Given this list of marker genes Atp6v1b2, Mnat1, Ino80 (INO80 complex subunit), Zfp970, Styxl2, Slc5a10, Pigw, Gtf3c4, Ido2, Pten, Alad, Lrp5, Ppp1r1c, Saysd1, Pusl1, Stat5b, Tbx20, Zfp966, Aff4, Nr3c1, Zfp979, Hspa5, Rad23b, Azin1, Retn, Rbm46, Gcsh, Arx, Txndc5, Cert1, Ltbp3, Prrc1, Zfx, Trip4, Sf3b1, Lin28a, Pnrc1, Rab19, Imp4, Morc4, Rab21, Trp63, Ccnt2, Nfrkb, Ypel2, Rnf150, Nampt, Il22ra1, Cubn, Zfp664, Usp9x, Pum2 (NCBI Gene Id 80913), Mon1b, Zfp967, Derl1, Atf1, Wdr26, Pptc7, Dennd4b, Sall1, Sp7, Rad21 (RAD21 cohesin complex component), Edem3, here is a description of the gene set: Genes predicted to be targets of miRBase v22 microRNA mmu_miR_6974_3p in miRDB v6.0 with MirTarget v4 prediction scores > 80 (high confidence targets). species: Mus musculus Mouse Gene Set: MIR_6974_3P from publication Chen Y, Wang X (PMID 31504780)